Given this list of marker genes Gpsm1, Stmn1, Met, Ripor1, Ripor2, here is a description of the gene set: species: Mus musculus Mouse Gene Set: GOBP_NEGATIVE_REGULATION_OF_GUANYL_NUCLEOTIDE_EXCHANGE_FACTOR_ACTIVITY Any process that stops, prevents or reduces the frequency, rate or extent of guanyl-nucleotide exchange factor activity.